The following is a description of a gene set: species: Homo sapiens Any apoptotic process in a neuron, the basic cellular unit of nervous tissue. Each neuron consists of a body, an axon, and dendrites. Their purpose is to receive, conduct, and transmit impulses in the nervous system. Human Gene Set: GOBP_NEURON_APOPTOTIC_PROCESS, and this is the list of marker genes: TRPC5, PCDHGC5, NGF, GRID2 (NCBI Gene Id 2895), SARM1 (NCBI Gene Id 23098, sterile alpha and TIR motif containing 1), EGLN1, PSEN1, BAX, NTRK2, COL6A3, MEF2C, FZD9, PIK3CA (phosphatidylinositol-4,5-bisphosphate 3-kinase catalytic subunit alpha), CDK5, CITED1, DIO3, MFSD8, PARP2, CASP6, PIGT, SIAH1, KCNB1, NPR2, SOD2, SLC1A1, NSMF, DNAJC5, CBLC, RAPSN, CORO1A, PLA2G3, SLC25A27, NDP, BCL2L1, TMBIM1, MIR181C (microRNA 181c), EPHA4, HTRA2, SPG11, MYB, CASP10, CNTF (ciliary neurotrophic factor), MINAR2, NEFL, ANGPT1, PTK2B, ALKBH1, TERT, FASLG, CFLAR, ISL1, COL6A1, PLXND1, EN2, CX3CL1, NPPC, BOK, FCGR2B, BBS10, ARMCX5-GPRASP2, ELK1, CX3CR1, CLU, VEGFB (NCBI Gene Id 7423), GBE1, OXR1, BNIP3, RHOA, RASA1, NRBP2, GPRASP3, NRP1, CLN3, ASCL1, POU4F1, TMTC4, RETREG1, HDAC3, CASP7, PCDHGC3, TYRO3, EPHA7, TP53, ADARB1, FAIM2, GPX1, POLB, LGMN, CASP14, PRODH, USP53, DAXX, DIABLO, HYOU1, BBC3, NFATC4, PHB1, FIS1, GAPDH, TOX3, FAM162A, PCSK9, BARHL1, PYCR1, CASP3, FADD, HIF1A, NR3C1 (NCBI Gene Id 389335), WFS1, CLN8, PPARGC1A (NCBI Gene Id 10891), LCN2, PRKN, GRIK2, SIX1, ATF2, TNFRSF21, NCSTN, GDNF, PRKCG, ST8SIA2, KDR, TMBIM4, MIR195, NGFR, APP, GDF5, CNTFR, GRINA (NCBI Gene Id 2907), TRAF7, SYNGAP1, MAP3K12, HSPG2, CTNNB1, CASP9, AIFM1, CCND1, JAK2, GRM4, TP63, SOD1, TMBIM6, GSK3B, PARK7, MAP2K4, TFAP2D, HRAS, CASP2, NUPR1, SCN2A, COL6A2, DRAXIN, CPEB4, RB1, MIR98, VSTM2L, FGF2, SNCA, XRCC2, TGFB2, FGF20, BDNF, PARP1, TREM2, XIAP, CDK5R1, CD2AP, ADNP, MIR200A, NR4A3, MCL1, PITX3, AGAP2, BACE1, GBA1, NOS1, CCL2, SNX6, CLCF1, NTRK1, BID, AATK, ARSG, NONO, UBB, ADCY10, KIF14, MIR132, ERBB3, KDM2B, TRIM2, ATN1, STAMBP, TFAP2A, MDK, GCLC, GFRAL, ADORA2A, EPG5, ROCK1, NF1 (NCBI Gene Id 646021), FAS, GRN, GMPPA, AIMP2, AXL, PINK1, EGLN3, CRH, DDIT3, AGTR2, HIPK2, CASP12, BTG2, UCP2, SET, TUBA1A, LONRF2, ADAM8, SNCB, AKT2, STXBP1, EGLN2, IL27RA, ZPR1, MAG, ABL1, TFAP2B, ZNF212, NAE1, RIPK1, CASP8, FBXO7, AKT1S1, ATP7A (NCBI Gene Id 613259), APAF1, NLRP1, EN1, PRNP, NMNAT1, MAP2K7, CASP5, GCLM, THAP11, KRAS, CASP4, NAIP, NTF4, SIX4, GSK3A, DKK1, MIR212, KCNQ3, AMBRA1, TGFB1, CEBPB, NR4A2, PCDHGC4, SIGMAR1, MAP3K11, BCL2L11, WNT1, RAD21, JUN, TNF, HRK, NDNF, BRAF, FYN, CHL1, MIR15B, MT3, THRB, HTR2A, NES, POU4F3, AARS1, G6PD, TP73, MSH2, SIRT1, ITGA1 (NCBI Gene Id 3672), DLX1, SEMA3E, FOXB1, MAP3K5, FOXO3, NTF3, SRPK2, MMP2, IL6ST, CCL3, ELP6, GATA3, UNC5B, BCL2, PPT1, ATM, TGFB3, IL10, PTPRZ1, MTNR1B, PRKCI, CRLF1, MECP2 (methyl-CpG binding protein 2), CIT, VPS54, UCN, FGF8, FBXW7, AKT1, LIG4, F2R, FPR2, ATP13A2, ATF4 (activating transcription factor 4), EGR1, FZD1